The following is a description of a gene set: The regulated release of acetylcholine by a cell. Human Gene Set: GOBP_ACETYLCHOLINE_SECRETION species: Homo sapiens, and this is the list of marker genes: ADORA2A, TACR2, SLC18A3, SLC44A4, CHRNA3